Given this list of marker genes Rcor1, Rab7b, Myb, Gp1ba, Uba5, Gp5, Tescl, Mpig6b, Kit, Mef2c, Gabpa, Cib1, Abi1, Prmt1, Flna, L3mbtl1, Gata1, Gp9, Sp1, Maf, Pip4k2a, Scin, Lox, Zfp385a, Sp3, Hmgb2, Nbeal2, Ptpn6, Eif6, Tesc, Pf4, Ptpn11 (protein tyrosine phosphatase, non-receptor type 11), Thpo, Kdm1a, Rabgap1l (RAB GTPase activating protein 1-like), Med1, Faxdc2, Tal1, Cnot4, Mturn, Gp1bb, Ep300, Wasf2, Sh2b3, Meis1, Gata2, Srf, Zfpm1, Pithd1, Fli1, Cdkn2b, Vps33b, Blvrb, Rbm15, here is a description of the gene set: studied in species Mus musculus The process in which a myeloid precursor cell acquires specializes features of a megakaryocyte. Mouse Gene Set: GOBP_MEGAKARYOCYTE_DIFFERENTIATION